Given this list of marker genes IRF6, TELO2, OFD1, POU4F1, FBXO11, ADNP, LMNA, FAM111A, H4C5, CRKL, MAPK1, TBX22, CDC42BPB, GRHL3, RSPO2, NXN, ZMPSTE24, SLC37A4, TAF4, SETBP1, COL7A1, DDX59, SPTBN1, AFF3, BCR, ROR2, MMP1 (NCBI Gene Id 4312), MID1, KMT2D, PRR12 (proline rich 12), here is a description of the gene set: Ankyloglossia studied in species Homo sapiens Human Gene Set: HP_ANKYLOGLOSSIA Short or anteriorly attached lingual frenulum, associated with limited mobility of the tongue.